The following is a description of a gene set: Human Gene Set: LEIN_NEURON_MARKERS Molecular approaches to understanding the functional circuitry of the nervous system promise new insights into the relationship between genes, brain and behaviour. The cellular diversity of the brain necessitates a cellular resolution approach towards understanding the functional genomics of the nervous system. We describe here an anatomically comprehensive digital atlas containing the expression patterns of approximately genes in the adult mouse brain. Data were generated using automated high-throughput procedures for in situ hybridization and data acquisition, and are publicly accessible online. Newly developed image-based informatics tools allow global genome-scale structural analysis and cross-correlation, as well as identification of regionally enriched genes. Unbiased fine-resolution analysis has identified highly specific cellular markers as well as extensive evidence of cellular heterogeneity not evident in classical neuroanatomical atlases. This highly standardized atlas provides an open, primary data resource for a wide variety of further studies concerning brain organization and function. Genes enriched in neurons in the adult mouse brain identified through correlation-based searches seeded with neuron cell-type specific gene expression patterns. from publication Lein ES, Hawrylycz MJ, Ao N, Ayres M, Bensinger A, Bernard A, Boe AF, Boguski MS, Brockway KS, Byrnes EJ, Chen L, Chen L, Chen TM, Chin MC, Chong J, Crook BE, Czaplinska A, Dang CN, Datta S, Dee NR, Desaki AL, Desta T, Diep E, Dolbeare TA, Donelan MJ, Dong HW, Dougherty JG, Duncan BJ, Ebbert AJ, Eichele G, Estin LK, Faber C, Facer BA, Fields R, Fischer SR, Fliss TP, Frensley C, Gates SN, Glattfelder KJ, Halverson KR, Hart MR, Hohmann JG, Howell MP, Jeung DP, Johnson RA, Karr PT, Kawal R, Kidney JM, Knapik RH, Kuan CL, Lake JH, Laramee AR, Larsen KD, Lau C, Lemon TA, Liang AJ, Liu Y, Luong LT, Michaels J, Morgan JJ, Morgan RJ, Mortrud MT, Mosqueda NF, Ng LL, Ng R, Orta GJ, Overly CC, Pak TH, Parry SE, Pathak SD, Pearson OC, Puchalski RB, Riley ZL, Rockett HR, Rowland SA, Royall JJ, Ruiz MJ, Sarno NR, Schaffnit K, Shapovalova NV, Sivisay T, Slaughterbeck CR, Smith SC, Smith KA, Smith BI, Sodt AJ, Stewart NN, Stumpf KR, Sunkin SM, Sutram M, Tam A, Teemer CD, Thaller C, Thompson CL, Varnam LR, Visel A, Whitlock RM, Wohnoutka PE, Wolkey CK, Wong VY, Wood M, Yaylaoglu MB, Young RC, Youngstrom BL, Yuan XF, Zhang B, Zwingman TA, Jones AR (PMID 17151600) species: Mus musculus, and this is the list of marker genes: SLC22A17, SNRPN, NORAD (NCBI Gene Id 647979), SYP, NAPB, ATP6V1G2, FAIM2, GPR162, GRIA4, KIFC2, CAMK2B, JAKMIP1, GRIA2, NEFL, CHN1, CPLX1, SYNGR3, CYFIP2, GAP43, SNAP25, RTN1, DISP2, MYO5A, DPP6, FLYWCH1, TRANK1, UNC80, MAP2K4, TUBA4A, MADD, CHGB, RAB6A, CAMK2A, MEG3, SYT1, BMERB1, EGR1, CX3CL1, SMARCA2, LHX9, ADD2, PRKACA (NCBI Gene Id 5566), NSG2, GABARAPL1, REPS2, CHST1, GRIN2B, ALCAM, PACSIN1, BEX1, SNHG11, CYRIA, TCAF1, NDRG4, UCHL1, PHF24, RYR2, NDFIP1, PRKAR1B, GABBR2, MAP2K1 (NCBI Gene Id 5604), YWHAG, LRP11, CALM2, CLSTN3, GRIA3, SH3GL2, PTPRN, FBXW5